The following is a description of a gene set: species: Mus musculus Collagen degradation Mouse Gene Set: REACTOME_COLLAGEN_DEGRADATION, and this is the list of marker genes: Col7a1, Ctsb, Col5a3, Mmp2 (NCBI Gene Id 17390), Col25a1, Mmp11, Col6a2, Furin, Col6a1, Mmp14, Col4a4, Col8a1, Ctsk, Mmp20 (matrix metallopeptidase 20 (enamelysin)), Col4a5, Mmp9, Col19a1, Col15a1, Col10a1, Mmp12, Col8a2, Col5a1, Col4a2, Col1a1, Mmp10, Mmp8, Col6a6, Col11a2, Mmp3, Col6a5, Tmprss6, BC051665, Col11a1, Col6a3, Col3a1, Col4a3, Col4a1, Ctsd, Col26a1, Col13a1, Col4a6, Try4, Col2a1, Mmp13, Col18a1, Col1a2, Mmp15 (matrix metallopeptidase 15), Mmp7, Phykpl, Mmp1a, Col12a1, Col5a2